The following is a description of a gene set: from publication Cui A, Huang T, Li S, Ma A, Pérez JL, Sander C, Keskin DB, Wu CJ, Fraenkel E, Hacohen N (PMID 38057668) species: Mus musculus Cytokines mediate cell-cell communication in the immune system and represent important therapeutic targets. A myriad of studies have highlighted their central role in immune function, yet we lack a global view of the cellular responses of each immune cell type to each cytokine. To address this gap, the authors created the Immune Dictionary, a compendium of single-cell transcriptomic profiles of more than 17 immune cell types in response to each of 86 cytokines (>1,400 cytokine-cell type combinations) in mouse lymph nodes in vivo. A cytokine-centric view of the dictionary revealed that most cytokines induce highly cell-type-specific responses. For example, the inflammatory cytokine interleukin-1β induces distinct gene programmes in almost every cell type. A cell-type-centric view of the dictionary identified more than 66 cytokine-driven cellular polarization states across immune cell types, including previously uncharacterized states such as an interleukin-18-induced polyfunctional natural killer cell state. Genes positively differentially expressed in cell type: Treg upon treatment with cytokine: IFN-β in mouse lymph nodes in vivo. Mouse Gene Set: CUI_TREG_IFNB_RESPONSE_UP, and this is the list of marker genes: Oas3, Parp12, Gadd45g, Cd47, Gbp8, B2m, Ifit1bl1, Ifi47, Dtx3l, Ifitm3, Ascc3, Psmb8, Igtp, Jaml, Epsti1, Tmbim6 (NCBI Gene Id 68309), Ms4a4b, Bst2, Rsad2, Itpr1, Slfn2, Tapbpl, Tor3a, Ttc39b, Ube2l6, Sidt1, Ifit2, Capza2, Parp14, Aida, 9930111J21Rik2, Ifi203, Ifih1, Hars1 (histidyl-tRNA synthetase 1), Adar, Gbp6, Fam111a, Nmi, Psme1, Tspan3, Idnk, Ly6e, Lgals3bp, Apobec3, Tlr7, Ifi27l2a (NCBI Gene Id 76933), Tgtp2, H2-Q4, Zup1, Tapbp, Daxx, Usf1, Pdia3, Isg20, Il12rb1, Phyh, Hmgn3, Mx1, Ifi44, H2-Q6, Cd86, Ddx24 (DEAD box helicase 24), Usp18, Cep57l1, Stat2, Gbp5, Aftph, Tap1, Gbp2, Hspa5, Psmb10, Oasl2, Trafd1, Morc3, Csrp1, Cybb, Irgm1, Itm2b, Chmp4b, Sdc3, Herc6, Marchf5, Trim21, Sell, Ifi213, Vps54, Fchsd2, Sp140, Psma2 (proteasome subunit alpha 2), Ifit1, Clec2d, Slc25a22, Grina, Znfx1, Ms4a4c, Nlrc5, Uba7, H2-T23, Irf7, Tmem192, Casp8, Hspa8, Tbrg1, Irf1, H2-K1, Dhx58, Nt5c3, Parp10, Wars1, St6galnac4, Cnp, Nampt, Ifi35, Phf11b, Trim12a, Ddx60, Inpp1, Xrn2, Svbp, Tap2, Ccrl2, Sp100, Parp9 (NCBI Gene Id 80285), Cnot6l, Rbl1 (RB transcriptional corepressor like 1), Mitd1, Ifi208, Atp8a1, Pttg1, Usp25, Xaf1, H2-T24, Gbp3, Stat1, Ccnd2, BC051226, Sp110, Ms4a6b, Lamp2, Phf11c, Psme2b, H2-T22, Gbp9, Ifi209, Dpp4, Pcgf5, Trim30a, Laptm4a, H2-Q7, Myd88, Trim26, Lgals9, Slfn8, Mycbp2, Cmpk2, B4galt5, Cxcl10, Ppp1r12a, Rgs1, Rtp4, Tasor2, Vars1, Ehd3, Shisa5, Irgm2, Gmppb, Selenow, Gpr65 (NCBI Gene Id 14744), Snx2, Mxd1, Gramd2b, Pml, Ifit3b, Rnf114, Trim12c, Oas2, Zc3hav1, Gng12, Tmem184b, Zbp1, Samd9l, Sgcb, Oas1a, H2-D1, Tut4, Ifit3 (interferon-induced protein with tetratricopeptide repeats 3), Hsh2d, Keap1, Clic4, Tspo, Tcstv4, Rfc3, Mndal, Trim30c, Oasl1, Wdr43, Evl, Irf9, Gbp4, Ifi214, Iigp1, Nsd3, Rnf139, Phf11a, Asb13, Parp11, Ifi206, Ogfr, Dbnl, Phip, Ncoa7, Tor1aip2, Psme2, Slfn1, Ly6a, Mov10, Grn, Rnf213, Naa20, Calhm6, Helz2, Eif2ak2, Trim30d, Gbp7, Rigi, Max, Ctss, Isg15, Slfn5, Zcchc2, Plaat3, Etnk1, Ppa1, Psma5, Gch1, Samhd1, Trim34a, Socs1, Smchd1, Trim25, Ppm1k, Psmb9